Given this list of marker genes HSF1, ELK1, RPL26, BCL2L1 (NCBI Gene Id 598), GTF2H5, CDKN1A, YAP1, WRN, TP53, HRAS, MAP3K20, CHEK2, RAD51, MDM2, XRCC5, CRYAB, TMEM109, XRCC6, TREX1, EGR1, TSPYL5, MIR21, ATR, KDM1A, CYBA, ZMPSTE24, TLK2 (NCBI Gene Id 11011), ATM, here is a description of the gene set: Any process that results in a change in state or activity of a cell (in terms of movement, secretion, enzyme production, gene expression, etc.) as a result of a gamma radiation stimulus. Gamma radiation is a form of electromagnetic radiation (EMR) or light emission of a specific frequency produced from sub-atomic particle interaction, such as electron-positron annihilation and radioactive decay. Gamma rays are generally characterized as EMR having the highest frequency and energy, and also the shortest wavelength, within the electromagnetic radiation spectrum. species: Homo sapiens Human Gene Set: GOBP_CELLULAR_RESPONSE_TO_GAMMA_RADIATION